The following is a description of a gene set: part of: Metabolism of steroid hormones In female vertebrates, estrogens control reproductive system development and reproductive functions (Payne AH and Hales DB, 2004). Reactome Pathway: Estrogen biosynthesis species: Homo sapiens, and this is the list of marker genes: HSD17B11, HSD17B14, HSD17B1, HSD17B2, CYP19A1, AKR1B15